Given this list of marker genes RBP7, LACTB2, CNOT1, EPB41L2, NINJ2-AS1, FAS, ASAH1, ZNF468, ZNF717, CACNG1 (NCBI Gene Id 786), PARN, ZKSCAN2, STX4, SLC24A1, NSMCE2, HSPH1, ITFG1, UTP4, RIDA, DNPH1, DEF8, ZNF334, SNTB2, H2AC8, SUCLG2, ANKRD13C, TM7SF3, C6orf52, AKTIP, GFOD1, GINS2, PCOLCE2, PPIL1, CNN3-DT, ZNF600, PNMA8A, HNRNPH3 (heterogeneous nuclear ribonucleoprotein H3), HDDC2, TMEM14C, LSM3, CIAO2B, IDH2, LYRM1, JPH1, BBS2, MSH6, POLB, RPL39L, TSC22D3, SHISA2, JAGN1, DERA, POLR3K, KCNQ5, VPS37A, NQO2, SELENOP, MPHOSPH6, AP1S2, FAM216A, CENPQ, MRPL15, TMEM242, CDT1, COX20, TATDN1, ACTA2, MARVELD1, DCAF13, MRAP2, PLA2G15, ZCCHC14, ROBO2, H1-2, SLC39A7, PABPC4L, ZNF43, CENPN, PIEZO1, PKP2, CBFB, FPGT, DUXAP9, LEPROTL1, CERS1, DNAJC3, INTS10, NRCAM, SLC1A1, FABP5, FBXW10, TRAPPC2L, HSD17B6, ANKRD46, MSMO1, UBXN8, MAST4, TBC1D16, MMAB, HOXA9, TPD52L1, RMI2, UBE2V2, ZNF83, C2orf74, AEN, HSD17B8, TENT4B, KCTD9, USP10, COQ9, PURPL, CBS, UQCC4, SAYSD1 (SAYSVFN motif domain containing 1), ANKRD26, TERF2IP, P4HA1, POMT1, C6orf226, LMBRD1, BTG2, ANXA4, PON2, TCF25 (NCBI Gene Id 22980), ARL2BP, DLC1, CEP20, TSEN2, KBTBD11, C1orf43, PKIA, ETFA, LINC00161, POLR1E, SLC30A5, PLOD2, THUMPD3, APRT, MRTFB, BFAR, LXN, NUBP1, ACADM, ERICH1, TMEM208, RGS2, DBR1, CHD7, TNFRSF11A, RPL32, BTN2A1, DERL1, CASK, DDHD2, ZNF700, SULT1A1, NAE1, KLHDC4, HOXA5, EMC8, CPNE3, MKRN2, IKBKB, ENOPH1, CHD9, C16orf87, PRAME, NUP210L, STK3, ANKRD11, BAALC-AS1, IQCG, SHCBP1, PPP5D1P, CRYM, FTO, XPC, ADI1, ST6GAL1, UAP1, TBC1D7, CHCHD4, DPYSL2, SOX7, CHMP1A, RNF8, ADAM9, TMEM141, CEP15, JPH3, SESN1, SNRNP25, PDCD10, UFL1, EBAG9, COX6C, SRRM2-AS1, here is a description of the gene set: Genes down-regulated in dendritic cells: CD8A versus ITGAM+. Murine Cytomegalovirus (MCMV) infection leads to early activation of various immune cells, including B and T lymphocytes, before the actual initiation of antigen-specific adaptive immunity. This activation is partly driven by innate cytokines, including type I interferon (IFN), which are induced early after infection. The objective of this study was to address the role of type I IFN in shaping early/innate B and T cell responses to a primary acute viral infection. In order to decipher the specific impact of IFN-I on cell subsets, we performed a genome-wide expression analysis on WT splenic B and CD8 T lymphocytes isolated from C57BL/6 mixed bone marrow chimera mice. This study complements series GSE39555, which focused on early responses of NK cells and of the two subsets of conventional dendritic cells. species: Homo sapiens Human Gene Set: GSE45365_CD8A_DC_VS_CD11B_DC_DN